Given this list of marker genes HIVEP3, AREL1, GAPDHS, PMP2, SNCB, LGR5, HOXA6, LRCH1, H2AC18, PHF20, PYY2, SAT1, PROM1, AIPL1, PCDHB17P, SNX19, ZNF410, IDI2-AS1, MAFF, MAP3K8 (mitogen-activated protein kinase kinase kinase 8), CLDND1, NPVF, NPPB, EHBP1L1 (EH domain binding protein 1 like 1), MCF2, MS4A3, LY6G6C, CADPS, SPRR2B, SLC6A7, AK5, ST18, PSG6, NAMPT (nicotinamide phosphoribosyltransferase), SPAG9, WDR62, PPM1B, SZT2, BCL10, CALCA, GRIK1, CD68, LRRTM2, REN (NCBI Gene Id 5972), PSMD11, KIAA0087, STK10, CYCS, KRT19P2, SLC43A1, GTPBP1, RARS2, ZNF287, TSR1, FLG, AEBP1, IFNA6, DPEP3, MYOD1, KCNN2, ZNF764, ERO1A, DCLK2, SSTR3, FAM224A, PRF1, OASL, SLC5A1, LCP1, ASIC2, ADRA2C, ATP4B, IL17RA, TPCN1, SSX1, MRPL52, BICDL1, IGHD, MAP3K3, SYCE1L, IGKV1D-13, RAE1, LIPE (NCBI Gene Id 3991), ZFYVE9, APCS, KCNQ4 (potassium voltage-gated channel subfamily Q member 4), TOM1, DOP1A, FCGR3B, TET3, RAB4B, FFAR3, UCP1, ASTN1, ALAS1, CIC, A1CF, SERINC2, TAF4B, IRGC, FAM204A, ADAP2, TRMU, GREM1, LARGE1, GAS8-AS1, GRK6, PDE1C, INSR, MEPE, GDF10, HRH2, GP9, PTPRJ, SMO, ERCC6, H6PD, NPY6R, RAB5B, CHRD, SLC8A2, LHCGR (luteinizing hormone/choriogonadotropin receptor), CD83, AGO2, DPT, IL36G, CYP4A11, FOLR2, SLC17A2, ADRA2B, TAT, KIR3DX1, FAM135A, OPHN1, SENP2, TSSK1B, SCN10A, PRDM13, ACTL7A, SCMH1, VAV2, TACR3, TRDN, IKZF5, SEMA7A, ZNF507, B3GALT2, WIPF1, IL10, PIGO, ATP2C1, ERN1, NRXN2, DDR2, PAX4, SLC7A1, ZFYVE16, NEUROD4, ACVR2B, HNF4A, SELL, EVI2A, MYO1A, GALR2, RNF208, SPTLC2, ZC3H12A, SH3TC2, GPR27, DDN, SDHD, CHAT, MS4A5, SLC19A1, TRIB1, ZNF770, SAMSN1, SLC34A1, RAMP3, TEX14, ITGA8, FNDC3B, DEFB4A (NCBI Gene Id 1673), MKRN3, CASP10, SFTPC, ATG9A, RAB40A, RFX4, CMPK1, PCDHA3, ZNF225, CRYM, COQ6, COL4A3, here is a description of the gene set: from publication Griffith AV, Fallahi M, Nakase H, Gosink M, Young B, Petrie HT (PMID 20064453) Human Gene Set: GSE18281_PERIMEDULLARY_CORTICAL_REGION_VS_WHOLE_CORTEX_THYMUS_DN studied in species Homo sapiens Genes down-regulated in thymus perimedullary cortical region versus the whole cortex. Interaction of hematopoietic progenitors with the thymic stromal microenvironment induces them to proliferate, adopt the T cell fate, and asymmetrically diverge into multiple T lineages. Progenitors at various developmental stages are stratified among different regions of the thymus, implying that the corresponding microenvironments differ from one another, and provide unique sets of signals to progenitors migrating between them. The nature of these differences remains undefined. Here we use novel physical and computational approaches to characterize these stromal subregions, distinguishing gene expression in microdissected tissues from that of their lymphoid constituents. Using this approach, we comprehensively map gene expression in functionally distinct stromal microenvironments, and identify clusters of genes that define each region. Quite unexpectedly, we find that the central cortex lacks distinctive features of its own, and instead appears to function by sequestering unique microenvironments found at the cortical extremities, and modulating the relative proximity of progenitors moving between them.